Given this list of marker genes RPS27P3, EIF4A1P10, SNRPGP15, XRCC6P2, PRPS1P2, DUX4L27, XKR7, CLSPN, TCEA1P2, EIF3LP2, SUMO2P1, DDX12B, RNFT2, ENSG00000262884, GDI2P2, VDAC2P5, RD3, ADRA1B, KIFC1, RPS24P19, CSNK2A3, SKIDA1, LINC01224, ARPC3P3, RALGAPA1P1, GPC1-AS1, HNRNPCP2, CICP27, JRK, PHC1P1, RPL23AP42, CLCNKA, PLXNA4, RPL10P6 (NCBI Gene Id 285176), SIAH3, MIR4664, RPS7P10, RPLP0P9, MT-TS2, TICRR, SPAG5, PGAM4 (NCBI Gene Id 554205), RPL35P2, LINC02067, HNRNPA3P6, COX6A1P2, GCSHP5, RPL7AP30, PDIA3P1, HNRNPA1P10, SPTBN5, EIF4HP1, NECTIN1, TPM3P5, RPL6P10, STAG3L5P, CLDN9, RPL6P27, OVOL1, TROAP, P2RY2, PFN1P11, TUBBP1, NINL, NAT8L (N-acetyltransferase 8 like), MYOM3, MIR29B2CHG, MGAT5B, FBN3, H3-5, SLC28A2, PSMA6P1, LINC02108, HNRNPA1P7, DNAJB6P1, MKRN3, RPL3P2, OCLNP1 (OCLN pseudogene 1), BRD7P2 (NCBI Gene Id 92549), MXRA7P1, PAX2, EIF4BP7, WASH4P, CCDC150, TUBAP2, SBK2, PIF1, WDR62, RPL4P4, RAMACL, DNAJC9P1, RPL24P4, DISP3, LINC00664, YWHAZP3, HSPD1P1, CNGB1, EEF1B2P3, LINC01609, LINC01001 (NCBI Gene Id 100133161), RPSAP54, RPSAP15, LEMD1-DT, RANBP1P1, SRP9P1, CYSRT1, YTHDF2P1, AFG3L1P, RBM25-AS1, RPS27P4, SRSF6P2, FOXI3, MAGEC2, PABPC3, EEF1A1P6, ANXA2P2, LINC01089, OBSCN, RPL7P9, NPM1P7, UBQLN4P1, ARMC10P1, TUBA5P, RPL31P4, ARHGEF34P, MT-TH (mitochondrially encoded tRNA-His (CAU/C)), BZW1P2, KRT8P3, POMK (protein O-mannose kinase), DLX4, SERBP1P5, SSUH2, EIF2S2P4, RPL26P30, MEMO1P1, CPLX2, HSP90AB3P, RPL4P5, RANP1, HSPB1P1, YWHAZP5, DNAH10OS, STAG3L3, ST13P6, CEP170P1, ID1, PBX2P1, PPIAP22, HASPIN, RPS7P11 (NCBI Gene Id 85540), SETP14, SPCS2P4, RCOR2, AHCTF1P1, GMPSP1, KCNH3, GOLGA2P5, DGKZP1, DDX12P, HMGB1P5, UCA1-AS1, DSCAM-AS1, EIF4EP2, DSTNP3, FAR2P1, GRIN2B, TMEM183BP, LINC02593, CCNF, H2BC12L, LHX4 (NCBI Gene Id 89884), HMGB1P6, RPS27AP16, PPP1R14BP3, CIT, ZNF114, LCN10, RASSF10, RPLP0P11, PRR13P5, DACT2, MIR1302-9HG, KSR2, SERBP1P1, IGSF23, PALM3, RPL22P1, SUMO2P21, FAM215B, LY6G5B, MKI67, ALPL, ATF4P4, PLEKHG4B, RNPS1P1, CELSR3, ATF4P3, PFN1P1, RPL10P9, FOXB1, PCBP2P2, KIF12, ULBP3, GGT2P, BPTFP1, SULT1A3 (sulfotransferase family 1A member 3), TGM7, GPAT4-AS1, DHFRP1, EIF4BP6 (eukaryotic translation initiation factor 4B pseudogene 6), LINC00958, RAB6D, FABP5P7, NPM1P27, THAP12P7, PACSIN1, LINC00265, MT-TL2, FGB, EIF3CL, YBX1P1, MAP3K9, TLK2P1, EVPLL, RTN3P1, RPS27AP5, PAX8-AS1, MIR600HG, LINC01873, MYBL2, RAP1GAP2, RECQL4, BANF1P3, ESPL1, ZDHHC8BP, MTX1LP, RPL36AP37, HS6ST1P1, UCA1, ENSG00000267053, SNORD86, ADGRL1, EIF1AXP1, ADGRL1-AS1, PROX2, UBE2SP2, LINC00319, CHCHD2P9, FAM3C2P, KIF18B (NCBI Gene Id 146909), ANK1, PSMC1P1, here is a description of the gene set: A bioinformatics pipeline to separate donor tumor and mouse stroma transcriptome profiles was devised and tested. To examine the molecular fidelity of PDX versus donor tumors, the authors compared mRNA differences between paired PDX-donor tumors from nine ovarian cancer patients. from publication Liu Y, Chanana P, Davila JI, Hou X, Zanfagnin V, McGehee CD, Goode EL, Polley EC, Haluska P, Weroha SJ, Wang C (PMID 31004097) Genes differentially expressed between PDX and donor tumor samples from nine ovarian cancer patients. Human Gene Set: LIU_OVARIAN_CANCER_TUMORS_AND_XENOGRAFTS_XDGS_UP species: Homo sapiens